Given this list of marker genes C1R, IFI6, MDK, GJA1, MYH11, CD81, IFI27 (interferon alpha inducible protein 27), C1S, MX1, KLK10, IFITM1, STAT1, TIAL1, TFDP1, CFH, FGA, IFITM3, HSPA1B, CD99, SOX9, APOL1, PIM2, ASS1, GPX2, VTN, ALDH2, PDLIM1, IRF7, here is a description of the gene set: Respiratory syncytial virus (RSV) is a mucosa-restricted virus that is a leading cause of epidemic respiratory tract infections in children. RSV replication is a potent activator of the epithelial-cell genomic response, influencing the expression of a spectrum of cellular pathways, including proinflammatory chemokines of the CC, CXC, and CX(3)C subclasses. Ribavirin (1-beta-D-ribofuranosyl-1,2,4-triazole-3-carboxamide) is a nontoxic antiviral agent currently licensed for the treatment of severe RSV lower respiratory tract infections. Because ribavirin treatment reduces the cytopathic effect in infected cells, we used high-density microarrays to investigate the hypothesis that ribavirin modifies the virus-induced epithelial genomic response to replicating virus. Ribavirin treatment administered in concentrations of 10 to 100 micro g/ml potently inhibited RSV transcription, thereby reducing the level of RSV N transcripts to approximately 13% of levels in nontreated cells. We observed that in both the absence and the presence of ribavirin, RSV infection induced global alterations in the host epithelial cell, affecting approximately 49% of the approximately 6,650 expressed genes detectable by the microarray. Ribavirin influences the expression of only 7.5% of the RSV-inducible genes (total number of genes, 272), suggesting that the epithelial-cell genetic program initiated by viral infection is independent of high-level RSV replication. Hierarchical clustering of the ribavirin-regulated genes identified four expression patterns. In one group, ribavirin inhibited the expression of the RSV-inducible CC chemokines MIP-1 alpha and -1 beta, which are important in RSV-induced pulmonary pathology, and interferon (IFN), a cytokine important in the mucosal immune response. In a second group, ribavirin further up-regulated a set of RSV- and IFN-stimulated response genes (ISGs) encoding antiviral proteins (MxA and p56), complement products, acute-phase response factors, and the STAT and IRF transcription factors. Because IFN-beta expression itself was reduced in the ribavirin-treated cells, we further investigated the mechanism for up-regulation of the IFN-signaling pathway. Enhanced expression of IFI 6-16, IFI 9-27, MxA/p78, STAT-1 alpha, STAT-1 beta, IRF-7B, and TAP-1-LMP2 transcripts were independently reproduced by Northern blot analysis. Ribavirin-enhanced TAP-1-LMP2 expression was a transcriptional event where site mutations of the IFN-stimulated response element (ISRE) blocked RSV and ribavirin-inducible promoter activity. Furthermore, ribavirin up-regulated the transcriptional activity of a reporter gene selectively driven by the ISRE. In specific DNA pull-down assays, we observed that ribavirin enhanced RSV-induced STAT-1 binding to the ISRE. We conclude that ribavirin potentiates virus-induced ISRE signaling to enhance the expression of antiviral ISGs, suggesting a mechanism for the efficacy of combined treatment with ribavirin and IFN in other chronic viral diseases. Genes up-regulated in A549 cells (lung carcinoma) upon infection with RSV (respiratory syncytial virus) and up-regulated by further treatment with ribavirin. studied in species Homo sapiens from publication Zhang Y, Jamaluddin M, Wang S, Tian B, Garofalo RP, Casola A, Brasier AR (PMID 12719586) Human Gene Set: ZHANG_ANTIVIRAL_RESPONSE_TO_RIBAVIRIN_UP